The following is a description of a gene set: Human Gene Set: GOBP_EPITHELIAL_TO_MESENCHYMAL_TRANSITION studied in species Homo sapiens A transition where an epithelial cell loses apical/basolateral polarity, severs intercellular adhesive junctions, degrades basement membrane components and becomes a migratory mesenchymal cell., and this is the list of marker genes: S100A4, DDX5, FERMT2, TGFBR1, MIR144, EPHA4, GLIPR2, MIR573, BMP7, SERPINB3, TGFBR3, ZNF703, JAG1, ACVR1 (NCBI Gene Id 90), FUZ, MDK, TGFB1, SPRED2, POLR1B, QKI, HGF, HAS2, LIMS1, TGFB1I1, SPRED1, SDHAF2, SMAD2, GSC, VASN (NCBI Gene Id 337957, vasorin), KLHL12, NCAM1, MIR145 (NCBI Gene Id 406937), LOXL2, GREM1, TIAM1 (TIAM Rac1 associated GEF 1), MIR519D, WNT5A (NCBI Gene Id 7474), MIR142, PDPN, DSG2, TGFB2, LDLRAD4, MSX2, MCRIP1, ALX1, DAB2IP, KAT8, KDM1A, GSK3B, HEY1, SMAD7, IGF1, USF3, NOG, RBPJ, VEGFA, SPSB3, EFNA1, EZH2, LRG1, WNT16, WWTR1, PDCD6, NOTCH4, KBTBD8, MARK1, BMP4, GATA3, TCF7L2, SFRP2, SNAI2 (snail family transcriptional repressor 2), MIR372, MSX1 (msh homeobox 1), IL6, FOXA2, MIR19B1, MIR326, PDCD4, TCOF1, MTOR, MIR19A, HDAC2, HEYL, NOTCH1, WNT4, MIR590 (microRNA 590), HMGA2, SNAI1, SFRP1, RFLNB, OLFM1, CTNNB1, IL17RD, WNT2, MIR18A, PTEN, HIF1A, SLC39A10, GCNT2, DAB2, ELL3, LEF1, MIR221 (microRNA 221), SPRED3 (sprouty related EVH1 domain containing 3), MIR222, TNXB, MIR379, SPRY1, ACVRL1 (activin A receptor like type 1), EOMES, EDN1, WNT8A, HNRNPAB, TBX5, PPP3R1, BMP5, PTK2, AXIN2, RGCC, POFUT2, NKX2-1, BCL9L, APLF, EMP2, SMAD3, ZNF750, BAMBI, BMP2, MIR130A, DDX17, PPP2CA, FOXA1, SPRY2, TGFBR3L, TMEM100, RTN4 (NCBI Gene Id 57142), TGFBR2, CRB2, TBX3, ROCK2, DACT3, ROCK1, AMELX, FGFR2, IL1B, OVOL2, LRP6, TBX20, MIR204, ADIPOR1, ADAM15, EPB41L5, FGFR1, TRIM28, NOLC1, COL1A1, MIR149, TASOR, MIR302B, FOXC1, HPN, WNT11, ISL1, MIR21, TWIST1, PEF1, MIR202, MIR29B1, SP6, DLG5, HEY2, LOXL3, SMAD4, ENG, ADAM8, FOXF2, TGFB3, AGT, FBXO11, CUL7, EDNRA, AKNA, SOX9, FGF8, FAM83D, SDCBP, TRIM62, SLC39A6, EPHA3, MAD2L2 (NCBI Gene Id 10459)